The following is a description of a gene set: Mouse Gene Set: REACTOME_NRIF_SIGNALS_CELL_DEATH_FROM_THE_NUCLEUS species: Mus musculus NRIF signals cell death from the nucleus, and this is the list of marker genes: Itgb3bp, Ncstn, Aph1b, Uba52, Psen1, Ngf, Rps27a, Psenen, Ngfr, Aph1a, Ubc, Uba52rt, Sqstm1, Ubb, Traf6